The following is a description of a gene set: species: Mus musculus Any process that results in a change in state or activity of a cell (in terms of movement, secretion, enzyme production, gene expression, etc.) as a result of a stimulus indicating the organism is under stress. The stress is usually, but not necessarily, exogenous (e.g. temperature, humidity, ionizing radiation). Mouse Gene Set: GOBP_CELLULAR_RESPONSE_TO_STRESS, and this is the list of marker genes: Htatsf1, Rpa1, Notch1, Gsk3b, Tmem259, Thg1l, Zmpste24, Grm3, Oprm1, Upf1, Pttg1, Bmf, Gba1, Flywch1, Zbtb1, Fgf10, Hsp90b1, Mgarp, Rest, Ube2t, Hmox1, Lrrc8e, Trim32, Msh3, Cfl1, Ddit3, Ifi203, Mtss1, Hdac6, Casp2, Taok2, Apoa4, Stc1, Gpr37l1, Mpg, Rwdd1, Dot1l (NCBI Gene Id 208266), Lig4, Rbbp4, Mrnip, Casp9, Mbtps1, Rps6ka6, Ptprs, Dnajc10, Bccip, Tmem117, Hspa8, Endog, Mcm5, Cbs, Fem1b, Parp2, Mir29c, Oprd1, Cdc5lrt5, Zkscan3, Pycr2, Grn, Mastl, Ier3, Aff4, St8sia1, Babam2, Bbc3, Inpp5f, Parp8, Apex1, Tlr4 (toll-like receptor 4), Gata5, Sin3a, Bcl2l2, Rragb, Gad2, Dnajb12, Ercc8, Inhbb, Vcp, Bcl6, Rec8, Eme2, Xrn2, Fancl, Igf2bp1, Ep400, Fbp1, Rad21, Tmem258, Brat1, Wdhd1, Prkaca, Pdia3, Marf1, Exo1, Dnaja3, Prkaa2, Enpp1, Abraxas2, Usp1, Atg13, Cebpb, Trim25, Chchd2-ps, Pex14, Sox4, Ppara (peroxisome proliferator activated receptor alpha), Xpc, Nefh, Selenos, Tpt1, Setd2, Tex12, Kcnd2, Morf4l1, Chek2, Apoe, Hikeshi, Palb2, Clu, Nploc4, Ubqln2, Tdg-ps, Tnfrsf11a, Faap20, Spp1, Reg3b, H2aj, Arg2, Tada1, Donson, Bach1, Glul, Anxa1, Tank, Stk33, Ppm1d, Eif2ak4, Ubac2, Ube2v2, Tfec, Meioc, Psmd10, Serp1, Sod3, Bdkrb2, Src, Fas, Rrm1, Btg2, Gstm3 (NCBI Gene Id 99537), Blm, Knl1, Atm, Creb3l1, Foxn3, Ripor1, Hmga1, Eif2ak3, Fnip1, Ube4a, Rfc1, Thbs4, Ubxn1, Csnk2a1, Rnaseh2a, Ero1a, Rragd, Ppp2r5c, Ubxn4, Abl1, Gck, Lhx1os, Gfap, Spindoc, Phf10, Cip2a, Mpnd, Chd1l, Akirin2, Derl1, Apex2, Tnf, Vhl, Pik3c2b, Smg1 (SMG1 nonsense mediated mRNA decay associated PI3K related kinase), Mapk15 (NCBI Gene Id 332110), Taf10, Cdk7, Sec16a, Mcm6, Kat2b, Baz1b, Dynll1, Nudt1, Psen1, Clspn, Rora, Nrep, Lcn2, Mid1, Wac, Npas2, Prkag2, Ulk1, Ajuba, Gfral, Rad51d, Arpp21, Myod1, Kat7, Ankzf1, Uhrf1, Rrp8, Slc25a14, Ttf2, Hif3a, Ern2 (endoplasmic reticulum to nucleus signalling 2), Bbs1, Nudt16l1, Mrgbp, Terb2, Jak2, Aim2, Ube2a, Cep164, Lyn, Rps3, Psme4, Usp47, Klhl15, Brd7, Ecpas, Prkce, Rock2, Nupr2, Ifi203-ps, Stxbp4, Psap, Yy1, Mcm2, Keap1, Neo1, Sycp1, Lrrc8c, Ccar2, Sfrp1, Dpf2 (double PHD fingers 2), Nlrp3 (NCBI Gene Id 216799), Sod2, Polg2, Has2, Fan1 (NCBI Gene Id 330554), Fanci, Lig1, Mylk, Id2, Brsk1, Cpeb4, Bcl2, Dna2, Mettl1, Alox5, Kdm6a, Sem1, Pgk1, Pot1b, Snai1, Timeless, Tmbim6, P4hb, Rragc, Nsmce3, Clcn2, Hmgcr, Bcl3, Dclre1c, Dapk1, Ager, Hdac5, Stt3b, Mc1r, Ilk, Recql, Morc2a, Slco2b1, Ptprf, Angpt4, Dnajb2, H13, Cysltr1, Neil3, Coro2b, Grem1, Hsp90ab1, Ifi214, Bfar, Uba6, Pnp, Hipk1, Batf, Mmp3, Epha2, Nop53, Dhfr, Prpf19, Dag1, Sprtn, Hnrnpk (heterogeneous nuclear ribonucleoprotein K), Nr4a2, Rad18, Fut8, Mir204, Atp1a1, Cbx3, Cryab, Cdc5l, D7Ertd443e, Sipa1, Cpeb2, Clec7a (NCBI Gene Id 56644, C-type lectin domain family 7, member a), Npc1l1, Gnb1, Mre11a, Ssrp1, Cdkn2d, Tcim, Rnf138rt1, Acd, Slu7, Elavl4, Xiap, Selenon, Ggn, Tmem129, Brd8, Zbtb7b, Axin2, Agap3, Mbtps2, Penk, Srpx, Ogt, Plekha1 (pleckstrin homology domain containing, family A (phosphoinositide binding specific) member 1), Rrm2b, Rgcc, Fancd2, Trpc2, Ppia, Dyrk1b, Smdt1, Cry1, Ticrr, Gabarapl1, Ctsl, Immp2l, Nox1, Hipk2, Snai2, Ptpn2, Pak5, Mapk8ip3, Slc4a11, Eme1, Mus81, Mcl1, Seh1l, Mcu, Neil2, Adam17 (a disintegrin and metallopeptidase domain 17), Foxm1, Hsbp1l1, Wdr76, Fbxo5, Gstm6, Serpinb6c, Pif1, Muc1, G6pdx, Stx2, Tbc1d7, Trap1, Gngt1, Ggt1, Ercc5, Tbc1d24, Foxo1, Nbn, Chac1, Hspa5, Spo11, Mcrs1, Zfp385a, Lars1, Map3k3 (mitogen-activated protein kinase kinase kinase 3), Steap3, Edem2, Dnm1l, Hsf1, Efhd1, Pik3c2a, Bcap31, Shld2, Tbx3, Sh3glb1, Bcl2a1c, Rhoa, Cdkn2aip, D1Pas1, Akt2, Os9, Ptprv, Atg14, Uba1y, Diaph2, Alkbh3, Ercc6l2, Polg, Primpol, Snw1, Arnt, Slc12a6, Agr2, Nek4, Emsy, Rtn4r, Grina, Yeats4, Ttc5, Tldc2, Phlda3, Gorasp2, Pdgfrb, Wnt9b, Spop, Ngb, Ptk2b, Ybx1, Pbrm1, Rfc2, Ado, Tardbp, Ell3, Nuak1, Mndal, Ifi205, Igf1r, Stau2, Mtarc1, Prr5l, Prkcg, Sel1l, Trp53inp1, Rnaseh2b, Tnp1, Pdcl3, Smarcad1, Elapor1, Klf10, Ambra1, Rasgrf1, Alox15, Marcks, Ass1, Syvn1, Dhx36, Ascc2, Ercc2, Nrros, Zfp976, Cert1, Taf5, Egfr, Pyroxd1, Mmp14, Ednra, Derl3, Mir7b, Pot1a, Nfatc2, Helb, Atad5 (ATPase family, AAA domain containing 5), Cdc7, Rbm4, Inip, Kash5, Smarca5, Vegfa (vascular endothelial growth factor A), Ddr2, Zfas1, Cd2ap, Gnb1l, Cryge, Cdc5lrt8, Suv39h1, Adm, Wrn, Ppp4r2, Zfp668, Nuak2, Tmed2, Abcb1a, Nfe2l2, Ndel1, Zgrf1, Creb3l2, Xylt1, Vav3, Man1a2, Tmem109, Ccdc117, Rad1, Xbp1, Plec, Hbb-bs, H2ax, Usp19, Mdm4, Clpb, Prkag3, Bmpr2, Usp3, Braf, Pak1, Pdx1, Crhbp, Bad, Slc29a1, Atf2, Oxr1, Srebf1, Wnt1, Ubqln4, Apbb1, Pdia4, Topors, Sphk1, Taok3, Txndc12, Gabarapl2, Twist1, Hmgn1, Atad3a, Nod1, Prkg2, Cyren, Crygd (NCBI Gene Id 27311, crystallin, gamma D), Hus1, Rmi2, Akr1b1, Stox1, Ambp, Trpv1, Ncoa7, Ccdc47, Mirlet7f-2, Oma1, Top2b, Mirlet7f-1, Dgcr8, Mlh1, Gpr155, Nedd4, Rnf169, Sp7, Dmc1, Rnf146, Cul4a, Ucp2, Dysf, Atxn7l3, Nr1h3 (NCBI Gene Id 99182), Dctpp1, Triap1, Ccng1, Ube2w, Nthl1, Shld1, Kdm6b, Akt1, Helq, Cdc5lrt9, Pink1, Tm7sf3, Card9, Asb11, Gsr, Csnk2a2, Usp51, Hspb1, Eef1d, Cdc14b, Dclre1a, Tsc1, Tnfrsf10b, Stk39, Nr1h2, Polh, Pms1, Ube2v1, Setd7, Htra2, Faap100, Rnf111, Tnr, Parp9, Pole3, Gnl1, Macroh2a1, Sesn1, Plscr1, Cst3, Wdr4, Atg5, Ruvbl2, Herc2, Rbbp7, Fh1, Casp3, Rtn4, Gjb2, Ubxn6, Zmiz1, Spred2, Zfp830, Sf3b3, Actl6a, Cat, Ufm1, Eif4g1, Pik3r4, Usp15, Mlst8, Herpud1, Cers2 (ceramide synthase 2), Prap1, Map3k13, Micu1, Scamp5, Cinp, Vasn (NCBI Gene Id 74207), Brca2, Chchd2, Fbxo44, Rad51c, Yod1, Phb2, Plin1, Nprl2, Paxx, Bard1, Hapstr1, Nol3, Drd2, Epas1, Rpl26, Abca7, Smpd3, Ndnf, Hic1, Bcl2a1d, Mgmt, Ikbkg, Epha4, Tigar, Vps13a, Dntt, Ifng, Ube2b, Usp13, Rnft1, Rbbp6, Mir451a, Flcn, Slc7a11, Tnrc6a, Rad23a, Cd74, Plk5, B3gat1, Pdgfd, Itpr1, Zbtb4, Nfat5, Ern1, Msh4, Smc3, Cdk5rap3, Calr3, Rnf168, Tdp2, Hmga1b, Klf4, Tmtc3, Nup62, Usp10 (ubiquitin specific peptidase 10), Fancg, Calr, Krt13, Zfyve1, Actb, Lig3, Brme1, Msra, Mt3, Sfn, Pdcd6, Etaa1, Dnmt3a, Serpinb6e, Rgma, Rnf121, Ankrd1, Skil, Radx, Folr1, Kptn, Epo, Msh5, Mad2l2, Gins2, Rnf183 (ring finger protein 183), Rev1, Inava, Slc9a1, Hp1bp3, Higd1a, Cdc5lrt1, Pex2, Stac, Arid1a, Sgk1, Usp9x, Dtx3l, Ddb1, Epc2, Trpv3, Faap24, Egln3, Map3k5, Afg2b, Dnaja1, Mapk8, Brip1, Chd2, Gm14151, Trrap, Nfatc4, Scly, Rad51ap1, Pole, Sde2, Tfeb, App, Cdk5, Pnpla8, Ddx5, E2f7, Atf6b, Pck1, Rpain, Fbln5, Angptl4, Rhbdd1, Ufc1, Opa1, 4921509C19Rik, 4933438K21Rik, Ube2d3, Inhba, Hspa1a (NCBI Gene Id 193740), Yme1l1, Ruvbl1, Stat3, Cited2, Svip, Smarcc2, Mcts1, Smarce1, Rbm38, Get4, Ctla4, Poli, Slx1b, Fgf1, Sel1l2, Tmigd1, Atp2a3, Erp27, Gadd45a, Smc5, Trex2, Tor1a, Rwdd3, Rad9a, Vrk2, Umod, Chordc1, Lamp2, Prdm9, Vps41, Npm1, Ifi213, Pik3c3, Alkbh2, Polr2i, Rexo4, Man1a, Lrp1, Hpf1, Mettl3, Prkd1, Net1, Tmco1, Spire2, Znhit1, Edem1, Hsbp1, Ascc1, Cdip1, Slc8a1, Mir29b-1 (NCBI Gene Id 387223), Crebrf, Trim13, Mpv17, Bcl7a, Lrrk2, Smc4, Ube2n, Smc2 (NCBI Gene Id 67947), Rnf185, Cadps2, Cdk6, Slc11a2, Il1a, Mapt, Nck2, Myo6, Hdac9, Kin, Parp16, Brsk2, Rnf167, Fam162a, Tlk1, Pias4, Smarcb1, Brcc3dc, Top2a, Gtf2h3, Ptgs2, Aqp11, Pola1, Aunip, Tnks1bp1, Trpv4, Sirt2, Mapk3, Nsmce2, Bid, Pmp22, Slc39a5, Mirlet7g, Sirpa, Aldh3b1, Hif1a, Pparg, Smarca4, Trp63, Jkamp, Flna, E2f1, Cr1l, Mdm2 (transformed mouse 3T3 cell double minute 2), Atp7a, Prkaa1, Sfr1, Arid2, Fech, Mir874, Rela, Alb (albumin), Tmbim4, Capn1, Rnf186, Snca, Egln2, Abi3 (NCBI Gene Id 66610), Ndrg1, Ddrgk1, Slc38a2, Nhej1, Sirt6, Bclaf1, Mmp9, Serp2, Prmt6, Crhr2, Max, Trip12, Dnajc18, Dyrk3, Yju2, Chuk, Htt, Rad17, Cpeb1, Scarf1, Fmn2, Rnf8, Dyrk2, Prkch, Eya1, Mapkap1, Prrx1, Hfe, Spata18, Slc25a24 (NCBI Gene Id 69910), Rcn3, Cav1, Fancm, Ctnna1, Wnk1, Vldlr, Cops3, Zfp217, Rbx1, Becn1, Phf1, Ercc6, Rtel1, Nod2, Cysltr2, Cd44, Chd4, Supt20, Gcgr, Hdgfl2, Apod, Smug1, Nsmce1, Xpr1, Btk, Mms22l, Rnf139, Cd36, Lamb2, Parp10, Bcl7c, Spi1, Cyp1b1, Trpa1, Smarcc1, Hsp90aa1, Cdk2, Fbxo22, Elp6, Trib3, Mcm4, Fbxo31, Gtf2h1, Nabp2, Ddias, Usp22, Ppp4c, Nos3, Diaph1, Casr, Apoa1, Casp1 (caspase 1), Daxx, Poln, Ddit4, Rev3l (NCBI Gene Id 19714), Ypel3, Slc52a3, Hyou1, Cdkn3, Rhob, Parg, Ccna2, Zfp365 (zinc finger protein 365), Man1b1, Map2k1, Capn3, Meak7 (MTOR associated protein, eak-7 homolog), Supt16, Slc35a4, Foxa1, Egln1, Zdhhc16, Mnat1, Brf2, Setmar, Pla2r1, Aktip, Mutyh, Mir214, Uba5, Actr8, Pdk1, Polk, Pidd1, Mb, Senp3, Usp45, Meiob, Atg4b, Naglu, Sar1b, Mir30b, Ogg1, Ascc3, Edn1, Erlec1, Rnaseh2c, Sqstm1 (sequestosome 1), Xab2 (NCBI Gene Id 67439), Ywhag, Tnc, Stub1, Ano1, Mapk9, Ddx3x, Moap1, Tpr, Ang, Xpa, Gins3, Hilpda, Pagr1a, Ptprd, Mcmdc2, Foxp1, Adcy8, Eif2ak1, Hdac3, Atrx, Slc2a4, Ctsk, Kif22, Pdia2, Comp, Dnajb9, Cbx1, Gps2, Slc39a4, Hdac10, Armt1, Alkbh1, Mtr (5-methyltetrahydrofolate-homocysteine methyltransferase), Babam1, Traip, Ppp4r3c2, Cdc5lrt4 (cell division cycle 5 like, retrotransposed 4), Cgas, Sirt7, Mup1, Omg, Stk11, Wrap53, Abcb10, Pias1, Alkbh7, Exd2, Depdc5, Ralb, Bcl2a1b, Slc2a1, Rnf103, Foxo4, Rnf126, Mael, Pml, Kcnk3, Mapk14, Bag6, Drd1, Nudt15 (NCBI Gene Id 214254), Mir137, Stk19 (NCBI Gene Id 54402), Wdr59, Slx4, Pttg1ip, Ripk2, Atp2a2, Prelp, Ripk1, Nacc2, Prmt1, Rnase4, Cdca5, Fancc, Myc, Stoml2, Poll, Pjvk, Met, Ercc1, Mtmr3, Txndc2, Herpud2, Nqo1, Bcl2a1a, Meaf6, Gtf2h2, Erp44, Acaa2, Serpinb6a, Aste1, Tet1, Plk3, Hras, Tspo, Oser1, Gfi1, Aptx, Rnf145, Esco2, Fkbp1b, Sgf29, Gabarap, Nabp1, Icmt, Phf13 (NCBI Gene Id 230936), Mmp2, Pold1, Tdg, Dusp10, Rad52, Tifab, Ing3, Rptor, Skp2, Abraxas1, Pik3r2, Mtor, Pdcd10, Scimp, Cygb, Atmin, Mtrex, Fbh1, Rtn4rl2, Vrk3, Kat6a (K(lysine) acetyltransferase 6A), Spire1, Oxsr1, Smchd1, Bcl2l11, Eef1e1, Castor1, Nccrp1, Fabp1, Taf12, Ier5, Sesn2, Nupr1, Ap5z1, Ppp2cb, Jmy, Nsmce4a, Bbs10, Epc1, Bcl7b, Zranb3, Gstp1, Vcpip1, Fam111a, Tti1, Mill1 (MHC I like leukocyte 1), Trp53, Scn7a, Tsc2, Ubr4, Kics2, Trim39 (NCBI Gene Id 79263), Mapk11, Mfsd2a, Shld3, Park7, Smc1a, Mef2c, Uchl5, Pak6, Uaca, Fancb, Nsd2, Eif2ak2, Vps72, Mcm8, Recql5, Qars1 (glutaminyl-tRNA synthetase 1), Tfpi2, Gata6, Prkcd, Myh13, Wdr45b, Relb, Chchd4, Swsap1, Erlin2, Slf1, Sdhd, Sirt4, Rad23b, Wnt16, Riox1, Ermp1, Il18rap, Uimc1, Adprs, Cdc45 (NCBI Gene Id 12544), Rad51, Calr4, Supt7l, Taf6, Pum2, Aifm1, Slc38a3, Sema4c, Map2k2, Nefl, Mir199a-2, Aplf, Pogz, Cul3, Eno1, Pdk3, Mlh3, Stk38, Impact, Yap1, Tipin, Dnajc15 (DnaJ heat shock protein family (Hsp40) member C15), Zfyve26, Ints7 (NCBI Gene Id 77065), Xrcc1, Mnt, Pbk, Bcl2l12, Eya4, Ap5s1, Dsc2, Syf2, Tex15, Brd4, Ppargc1a, Spidr, Mpo, Endov, Ufl1, Trem2, Dnajb1, Hmces, Actr2, Fbxw7, Jun, Cbx8, Kat5, Prdx2, Setd1a, Ntrk3, Ins2, Gigyf2 (NCBI Gene Id 98689), Gstm5 (glutathione S-transferase, mu 5), Kmt5c, Pex10, Mir434, Adam8, Rbm11, Pole2, Kmt5b, Otub1, Cdc5lrt7, Tmem161a, Recql4, Iffo1, Ino80c, Ung, Rad54b, Fam168a, Chek1, Smyd2, Eef2k, Rint1, Wfs1, Ppef2, Clgn, Bend2, Ptgis, Apc, Pds5a, Fxn, Ywhaz, Szt2, Tbx2, Atf3, Mapkapk2, Asf1a, Erp29, Pick1, Uri1, Pds5b, Mir9-1, Rpap2, Ddx11, Polq, Neil1, Chaf1a, Ifi208, Fcgr2b, Apaf1, Marchf6, Bmyc, Pex13, Tgfb2, Pwwp3a, Tmem238l, Letm1, Dtl (NCBI Gene Id 76843), Mybbp1a, Cul4b, Hmga2, Usp7, Ube2j1, Uba1, Pak2, Peli1, Ppif, Spred1, Huwe1, Zfp277, Pcbp4, Nf1, Clca1, Fbxo45 (NCBI Gene Id 75407), Fmr1, Usp28, Swi5, Tmub2, Irak1, Romo1, Serpinb6d, Wnk3, Mir100, Tmx1, Parpbp, Clec16a, Srebf2, Tmub1, Mstn, Aen, Cbx5, Tmem67, Dclre1b, Mtch2, Uba7, Tonsl, Fis1, Dhx9, Zbtb40, Mir29b-2, Hspd1, Stk-ps2, Taf5l, Eid3, Bak1, B2m, Map2k4, Xrcc3, Optn, Mbtd1, Ugt1a1, Aqp5, Sp100, Pcgf2, Hmox2, Vash1, Chchd6, Map2k3, Creb3l3, Msh6, Tnfrsf1b, Plin2, Brcc3, Trim28, Parp1, Cdkn2b, Pacrg, Klhdc10, Tgfb1 (NCBI Gene Id 21803), Nscme3l, Wipi2, Axl, Rfc4, Mapk13, Pkd2, Bmp4, Tnfrsf1a, Nprl3, Hsf3, Chl1, Ecrg4, Atrip, Morf4l2, Eya2, Fto, Ndufs6, Sf3b5, Cep290, Mir99a, Cidea, Uvssa, Mcm7, Atp13a2, Cxcl12, Rasa3, Usp16, Lmna, Ackr3, Agt, Mgst1, Nucks1, Ino80d (INO80 complex subunit D), Man1c1, Igfbp6, Nrde2, Prkra, Rif1, Fnip2, Cbl, Cradd, Hmgb1 (NCBI Gene Id 15289), Rfc3, Clock, Gch1, Rtca, Spdya, Tert, Ngfr, Prkdc, H2-M3, Gen1 (NCBI Gene Id 209334), Macrod2, Macrod1, Usp25, Ppp4r3c1, Aif1, Dhrs2, Mapkapk5, Pik3cb, Rbx1-ps, Dele1, Rfwd3, D130043K22Rik, Sar1a, Zcwpw1, Sycp3, Pcna, Ccnd1, Majin, Tdp1, Rbm24, Plin3, Pmaip1, Cfap410, Sumo1, Polm, Stc2, Dnajb14, Manf, Mif (macrophage migration inhibitory factor (glycosylation-inhibiting factor)), Usp33, Prkn, G6pd2, Grm2, Trp53bp1, Pik3r1, Rnf34, Abcc9 (ATP-binding cassette, sub-family C member 9), Map3k20, Ubxn8, Mcm3, Serinc3, Wipi1, Parp6, Topbp1, Lncbate10, Eya3, Pclaf, Ifi209, Abcd1, Arhgef10l, Srxn1, Il1b, Ubqln1, Slc1a1, Gcn1, Cops5, Rnf5, Vrk1, Setx, Kremen1, Eny2 (NCBI Gene Id 72036), Scap, Mtarc2, Nme8, Taf6l, Mbd4, Grb2, Wdr24, Myof, Wdr45, Wnt4, Kcnj8, Faf2, Ddb2, Rasgrf2 (RAS protein-specific guanine nucleotide-releasing factor 2, NCBI Gene Id 70739), Vapb, Aifm2, Cdc5lrt6, Selenok, Dab2ip, Thy1, Cftr, Exosc10, Edem3, Gas6, Taf2, Slc25a23, Prdx1, Sod1, Xrcc6, Rbl1, Paxip1, Ppp4r3b, Bex1, Rmi1, Flot1, Atf4, Rpa2 (NCBI Gene Id 99984), Casp12, Wnt2b, Mgme1, Plk2, Trpm2 (transient receptor potential cation channel, subfamily M, member 2), Lonp1, Sfpq, Rfc5, Kcnk2, Mirlet7d (microRNA let7d), Asns, Pdk4, Dyrk1a, Nampt, Usp14, Hltf, Exo5, Pex5, Ddah1, Plk1, Mios, Nme3, Smarcd2, Ercc4, Rhno1, Cib1, Foxo3, Fen1, Mir9-3, Cdk9, Ucp1, Bax, Fads2, Shprh, Mcm9, H2ac25, Slc34a1, Bag3, Kdm1a, Saxo1, Fads1 (fatty acid desaturase 1), Eepd1, 4930447C04Rik, Mst1, Cdk1, Nhlrc1, Hsf2bp, Nipbl, Alkbh8, Dnajc3, Atg7, Wdr48, Hk3, Ccnk, Fzr1, Ifi211, Carlr, Tbl2, Zc3h12a, Mir9-2, Tiprl, Pms2 (NCBI Gene Id 18861), Pak4, Fer, Bcl2l1, Rad51b, Ppp1ca, Hdac2, Pdia6, Cetn1, Nbr1, Rtn4rl1, Morc3, Mapk7, Tnfaip3, Ep300, Faf1, Hspb8, Zbtb38, Rad9b, Txn1, Ash2l, Tcf7l2, Ndp, Terb1, Trip13, Cep63, Mir668, Zswim7, Ercc3 (excision repair cross-complementing rodent repair deficiency, complementation group 3), Prdx3, Ezh2, Srf, Spata22, Coq7, Itfg2, Ube4b, Rraga, Fbxo17, Pnpt1, Mief1, Ing4, Gstm7, Fbxo4, Ppard, Bmal1, Mdc1, Msh2, Polb, Susd6, Ppp4r3a, Ptn, Rbbp8, Anks4b, Map2k7, Trex1, Hgf, Shisa5, Cebpg, Ireb2 (NCBI Gene Id 64602), Ppp1r10, Npepps (aminopeptidase puromycin sensitive), Hus1b, Hrk (harakiri, BCL2 interacting protein (contains only BH3 domain)), Atxn3, Mapk1, Pierce1 (piercer of microtubule wall 1), Khdc3, Hspa1b, Fbxo27, Fbxo2, Igtp, Wrnip1, Ninj1, Gas2l1, Mapk8ip2, Tex264, Bnip3l, Thbs1, Hinfp, Pex12, Slf2, Msl2, Kmt5a, Ncoa6, Cdkn1b, Xrcc4, Kdm4d (lysine (K)-specific demethylase 4D), Ercc6l, Nuggc, Kras, Ficd, Kat2a, Taok1, Fos, Ppp1r15b, E230001N04Rik, Trp73, Ifi204, Cartpt, Eif2b5, Bcl2l10, Neurl4, Klf2, Creb3, Amfr, Tfpt, Gdf15, Pak3, Top3a, Becn2, Slc8a3, Pcsk9, Cntf, Ooep, Atp2a1, Otud4, Scara5, Brca1, Serpinb6b, Gins4, Psmc6, Men1, Acer2 (NCBI Gene Id 73682), Gtf2h4, Smc6, Foxa3, C1qbp, Ect2, Ptpn1, Egr1, Nek1, Oard1 (O-acyl-ADP-ribose deacylase 1), Tmem33, Sdf2l1, Nkx3-1 (NK3 homeobox 1), Niban1, Ifi207, Upp1, Rassf1, Poldip2, Bnip3, Prkag1, Dpf1, Mms19, Actr5, Nek11, Ifi206, Ctc1, Avpr1a, Ak4, Fignl1, Marchf7, Ddx1, Ino80, Psmd14, Tada3, Crebbp, Pawr, Pnkp, Rcsd1, Fus, Canx, Adrb2, Matn2, Pold2 (polymerase (DNA directed), delta 2, regulatory subunit), Mcm10, Nrbf2, Samhd1, Cdkn2a, Smarca2, Sirt1, Ubxn2a, Trpc6, Dpf3, Eno1b, Lrig2, Etv5, Pten, Pdk2, Cetn2, Rad54l, Xrcc2, Slc7a5, Lpcat3, Hrob, Stat6, Rnf152, Fancf, Xrcc5, Pigbos1, Foxred2, Stk26, Ube2k, Stx4a, Gpx5, Rps27l, Gap43, Ptprk, Dmap1, Stk24, Zmynd8, Zmat3, Rad21l, Tlk2, Qrich1, Atxn7, Bhlha15, Cdkn1a, Ccs, Map1b, Ppargc1b, Rbbp5, Aqp3, Morc2b, Bmpr1a, Arl6ip5, Pold3, Vkorc1l1, Crip1, Aqp2, Eif4ebp1 (NCBI Gene Id 13685), Crygf, Zfp36l1, Ufd1 (NCBI Gene Id 22230), Commd1, Taf7, Sgta, Firrm, Atr, Pik3ca, Ces1d, Kdm2a, Zfp580, Atf6, Nrg1, Comt, Aqp1, Ino80b, Nck1, Bod1l, Lrrc8d, Rpa3, Cenps, Krt20, Tmtc4, Errfi1, Derl2, Ybx3, Socs5, Dek, Mgat3, Smarcal1, Cirbp, Ints3, Ei24, Chka, Rad50, Akt3, Lipe, Rnf138, Cln3, Map4k4, Chaf1b, Fndc1, Ccdc13, Ret, Fanca, Gpr37, Ikbke, Paqr3, Gtf2h5, Terf2ip, Nlk, Zbtb7a (NCBI Gene Id 71606), Stk25, Dcun1d5, Map3k7, Cybb, Insig1, Ehmt2, Scn11a, Mag, Tfap4, Jagn1, Rnft2, Chrna4, Atg10, Map1lc3a, Aup1, Cenpx, Ube2e2, Actl6b, Pycard, Suv39h2, Was (NCBI Gene Id 97782), Rsl1d1, Insig2, Terf2, Pdgfra, Bpgm, Smarcd1, Ubr5, Scn2a, Ripk3, Parp3, Pold4, Ywhae, Sec61bl, Fbxo6, Smarcd3, Nono, Sesn3, Nfe2l1, Taf9, Map2k6, Eif2s1, Top3b, Fcor, Sec61b, Bok, Il6, Eif2a, Dap, Cdc5lrt10, Ube2g2, Bmt2, Npas4, Fyn, Ptpn11, Ube2j2, Ppp1r15a, Nfrkb, Rack1, Ankle1, Uvrag, Mta1, Pla2g6, Sncg, Cspg5, Prdx5, Traf6, Ucn3, Map1lc3b, Spring1 (SREBF pathway regulator in golgi 1), Ubxn10, Erlin1, Pycr1, Dgkz